The following is a description of a gene set: from publication Smith MW, Yue ZN, Geiss GK, Sadovnikova NY, Carter VS, Boix L, Lazaro CA, Rosenberg GB, Bumgarner RE, Fausto N, Bruix J, Katze MG (PMID 12591738) Potential marker genes specifically up-regulated in the majority of hepatocellular carcinoma (HCC) tumors. Human Gene Set: SMITH_LIVER_CANCER Hepatocellular carcinoma (HCC) is a common primary cancer associated frequently with hepatitis C virus (HCV). To gain insight into the molecular mechanisms of hepatocarcinogenesis, and to identify potential HCC markers, we performed cDNA microarray analysis on surgical liver samples from 20 HCV-infected patients. RNA from individual tumors was compared with RNA isolated from adjacent nontumor tissue that was cirrhotic in all of the cases. Gene expression changes related to cirrhosis were filtered out using experiments in which pooled RNA from HCV-infected cirrhotic liver without tumors was compared with pooled RNA from normal liver. Expression of approximately genes was analyzed using the advanced analysis tools of the Rosetta Resolver System. This analysis revealed a set of 50 potential HCC marker genes, which were up-regulated in the majority of the tumors analyzed, much more widely than common clinical markers such as cell proliferation-related genes. This HCC marker set contained several cancer-related genes, including serine/threonine kinase 15 (STK15), which has been implicated in chromosome segregation abnormalities but which has not been linked previously with liver cancer. In addition, a set of genes encoding secreted or plasma proteins was identified, including plasma glutamate carboxypeptidase (PGCP) and two secreted phospholipases A2 (PLA2G13 and PLA2G7). These genes may provide potential HCC serological markers because of their strong up-regulation in more than half of the tumors analyzed. Thus, high throughput methods coupled with high-order statistical analyses may result in the development of new diagnostic tools for liver malignancies. species: Homo sapiens, and this is the list of marker genes: ZBTB18, TOB1, TOP2A, DDC, PGRMC1, PPP2R5A, TBX3, MTFR1, CDKN3, NCOA2, IFT20, GSTM4, SEMA5A, ADIPOR1, HJURP, TP53BP2, SDHC, RAB4A, CXCL8, IMPA2, NHP2 (NHP2 ribonucleoprotein), CHPT1, PEX2 (NCBI Gene Id 5828), SDC2, AURKA, TMEM106C, AMACR, CENPF, PIR, GSTA4, ACACA, COPS5, CTNNA2, ALDH1A1, TBCE, PDCD5, PLA2G12B, FDPS, HTATIP2, TNFAIP3, BNIP3, ANXA7, PAK4, RHOBTB3 (Rho related BTB domain containing 3), PMVK, PFDN6, BMI1